Given this list of marker genes PRDX1, ASPH, PREPL, MTRR, PPM1B, MMADHC, MMACHC, SLC7A9, HCFC1, CAMKMT, CBS, AASS, ABCD4 (NCBI Gene Id 5826), LMBRD1, SLC3A1, MTHFR, MTR, here is a description of the gene set: An elevated level of a sulfur-containing amino acid in the urine. species: Homo sapiens Human Gene Set: HP_INCREASED_SULFUR_AMINO_ACID_LEVEL_IN_URINE Increased sulfur amino acid level in urine